The following is a description of a gene set: Mouse Organogenesis Cell Atlas (MOCA) DE_gene_main_cluster.csv, fold.change>=1.5, qval<0.05, pval<0.05 studied in species Mus musculus from publication Cao J, Spielmann M, Qiu X, Huang X, Ibrahim DM, Hill AJ, Zhang F, Mundlos S, Christiansen L, Steemers FJ, Trapnell C, Shendure J (PMID 30787437) Mouse Gene Set: DESCARTES_ORGANOGENESIS_ENDOTHELIAL_CELLS, and this is the list of marker genes: Tmem88, Arap3, 9930012K11Rik, Gm32688, Ripply3, Klhl4, Uprt, Dusp2, Stab2, Shank3, Prkd2, Pecam1, Enpp3, Col4a1, Yes1, B630019A10Rik, 9630010A21Rik, Niban2, Gm13387, Sox18, Gm16897, Nmi, Lpar6, Pgm2, Col4a2, D630008O14Rik, Nos3 (nitric oxide synthase 3, endothelial cell), Smim33, S1pr1, Arhgap27, Shroom2, Tek (NCBI Gene Id 99999), 8030487O14Rik, E030026E10Rik, Gm36503, Numb, 5830444B04Rik, Tnfrsf11b, Arhgef15, 8030442B05Rik, Ralb, Dusp5, Bik, Dipk2b, Jcad, Epas1, Sox7 (SRY (sex determining region Y)-box 7), Egfl7, Msn, Gm30648, Plaur (plasminogen activator, urokinase receptor), Kcne3, Ets1, Gpr182, Adora2a, Flt1, Notch4, Bmx, Oit3, Arhgef3, Scarf1, Gm22060, Ppp1r16b, Pkn3, Cd38, Rapgef3, Cav1, C130074G19Rik, Kcnj2, Plk2, Klf2, Mmp28, Trpc3, Esm1, Lck, N4bp3, Rapgef5, Myo1h, Pdgfb, Afap1l1, Ppp1r13b, Icam2, Pced1b, Adamtsl2, Cd109, Arhgap29, D5Ertd615e, Ifi203-ps, Dock6, Cav2, Itpr3, Usp43, Zfp366, Tjp1, Elk3, Taok2, Gm36816, Dock9, Adgrf5, Tmem255a, Cyyr1, Gja4, Ptk2, Rasip1, Acer2, Sema3g, Tdrp, Tcim, Gimap6, Tspan15, Pear1, Slfn5, Foxo1, Ccdc152, Snrk, Kctd12b, Gimap4, Adgre5, Plvap, Il27ra, Eng, Calcrl, Kdr, Rgs3, AU021092, Adarb1 (NCBI Gene Id 76716), Sh3bp5, Ushbp1, Gimap8 (NCBI Gene Id 243374), Gja5, Tspan14, Cd81, Depp1, Aplnr, Myzap, Htra3, Prex2, Map4k5, Gm26236, Nlrc3, Myct1, Rigi, She, Fgd5, Tbxa2r, Hbegf, Cdh5, Dll4, Fam43a, Adam15, Gdpd3, Col15a1, Mast4, Pcdh12, Clec14a, Ramp2, Car8, Rasgrp3, Tmem204, Cavin3, Col18a1, Btnl9, Prkch, Npr1, Pcsk2os2 (NCBI Gene Id 378775), Bcl6b, F11r, Hdac7 (NCBI Gene Id 56233), Abcb1a, Sh2d3c, Ehd2, Tm4sf1, Efna1, Grap (GRB2-related adaptor protein), Serpine1, Rin1, Tlr3, Clec1a, Cpne8, Tie1, Tjp2, Adh6b (alcohol dehydrogenase 6B (class V)), Pde8a, Arhgap18, Plpp1, Vsig2, Erg, Itpr2, Gm12426 (NCBI Gene Id 102634926), 4930512B01Rik, Gimap9, Pald1, Adam19, Cd34 (NCBI Gene Id 98592), Cldn5, Bcl2, Lrrc8c, Hspg2, Esam, Card10, Plxnd1, Adgrl4, Stap2, Adcy4, Cd40, Csgalnact1, Emcn, Sparc, Apln, Gm25410, Prcp, Garre1, Epha2, Ets2, Rhoj, Gm15587, Mmrn2, Flt4, Dysf, Nherf2, Gm15614, Nr4a1, Map4k2, Ptprb, Ankrd33b, 9530078K11Rik, Sox17, Vash1, Asah2, Nfkbia, Thsd1, Snord104, Grk5, Cd93, Peak1, Trim16, Dgkh, Tfpi, Chst7, Rin3, Madcam1, Galnt4, Vwa1, Cables1, Plekhg1, Flnb, Clca2, Itga2, Myo6, Eogt, Scn4b, Fam124b, Robo4, Mall, Slc26a10, Cdk17, Cdc42bpb, Acvrl1 (NCBI Gene Id 11482), Hapln1, Ldb2, Edn1, 4930573H18Rik, Ica1, Cgnl1, Foxq1, Gimap1, Zfp69, Plac1, Prr5l, Rsad2, Ptprm, Ccm2l, Apold1, Disc1, Ecscr, Kank3, Ppm1f (NCBI Gene Id 71214), Gsg1, Fmnl3, Gm12503, Exoc3l, Colgalt2, 4632418H02Rik, Nfkb2, Ece1, Osmr, Itpkb, Gbp9, Fzd4, S100a16, Rhob, Limch1, BC028528 (cDNA sequence BC028528)